The following is a description of a gene set: studied in species Homo sapiens Genes up-regulated in comparison of unstimulated dendritic cells (DC) at 0 h versus DCs stimulated with LPS (TLR4 agonist) and R848 for 8 h. from publication Napolitani G, Rinaldi A, Bertoni F, Sallusto F, Lanzavecchia A (PMID 15995707) Human Gene Set: GSE2706_UNSTIM_VS_8H_LPS_AND_R848_DC_UP Toll like receptors (TLRs) sense microbial products and initiate adaptive immune responses by activating dendritic cells (DCs). Since pathogens may contain several agonists we asked whether different TLRs may synergize in DC activation. We report that in human and mouse DC TLR3 or TLR4 potently synergize with TLR7, TLR8 or TLR9 in the induction of selected cytokine genes. Upon synergistic stimulation, IL-12, IL-23 and Delta-4 are induced at levels 50-100 fold higher than those induced by optimal concentrations of single agonists, leading to enhanced and sustained TH1 polarizing capacity. Using microarray analysis we show that only 1.5% of the transcripts induced by single TLR agonists are synergistically regulated by combinations of TLR4 and TLR8 agonists. These results identify a combinatorial code by which DCs discriminate pathogens and provide (suggest) a rationale to design adjuvants for TH1 responses. Series_overall_design: 3 untreated, 3 treated with LPS at 2h, 3 treated with LPS at 8h, 3 treated with R848 at 2h, 3 treated with R848 at 8h, 3 treated with LPS + R848 at 2h, 3 treated with LPS + R848 at 8h, and this is the list of marker genes: IVD, CNPY3, SMARCA4, TK2, RAB34, PGPEP1, MCUR1, TULP4, KLHL21, VSIR, MBNL3, DOK1, CD33 (CD33 molecule), VPS26B, MEA1, DTD1, PDCD4-AS1, ICMT, CIITA, H2AX, PPIH, CCDC102B, PKN1, ACAA1, INTS10, ACSS2, EFHD1, HDGF, USB1, SLC49A4, TTC3, EPRS1, NDUFA12, MRPL48, STAG3, TXNL4A, SLC7A8, DCLRE1C, DDX41, GPS1, INPPL1, KDM4B, CEP78, SLC8A1, ZNF581, IARS2 (NCBI Gene Id 55699), NUP85, TWF2, LEPROTL1, KLHL42, APRT, CD1C, SH2D3C, ZNF641, SLC39A10, CEP57, OCEL1, PDK3, ZNF184, GLRX5, STX10, ARSD, PON2, NHP2, ETFRF1, NSL1 (NSL1 component of MIS12 kinetochore complex), TTC7A, HAGH, UNG, TBC1D14, NFIA, IGF1R, AP1M1 (NCBI Gene Id 8907), ACAT1, SMARCC1 (SWI/SNF related, matrix associated, actin dependent regulator of chromatin subfamily c member 1), NUP133, LIN37, CTBP2, FRMD4A, NDUFA8, HK1, MPST, CARS2, ELAC2, ZMYND19, MSH6, CLSTN1, OIP5-AS1, TRAPPC2L, GRHPR, TBC1D22A, PRCP, GNPDA1, PNPO (NCBI Gene Id 55163), PLA2G12A, GSTK1, MRE11, TMEM107, TSHZ3, SPOP, VPS37A, TRIM14 (tripartite motif containing 14), RPL13A, PGM2L1, CAMK2G, IFNAR1, LBR, PHC2, CCDC107, ARL3, FAM118B, CDCA7L, ELMOD2, MRPS5, SLC12A2-DT, C11orf24 (NCBI Gene Id 53838), AGAP3, IRF2BP2, RPA1, ITFG2 (NCBI Gene Id 55846), SLC38A9, RRM2B, TPST2, SHCBP1, CLEC10A, UQCRC1, CRTAP, YIPF2, RAB33A, GMPS, CBFB, HAUS4, NDC1, HSPBAP1, IL17RA, IRF4, MRAS, MRPL11, ZNF609, SLC45A4, DENND1C, DAB2, MARCHF8, SLC4A11, DNAJC9, AQP3, PWAR5, TMEM65, TPRG1L, CCDC14, FDX2, B3GLCT, POP5, HACD2, CLEC7A (NCBI Gene Id 64581), ATP5PO, RIOX2, SAE1, PHF14, CTNS, CCDC92, MAGOH-DT, UFC1, SLC12A7, PRPSAP1, LPCAT4, MEF2D, NSMAF, MRPS9, AP4B1, CERK, FAM111A, HEBP2, PARP1, MBP, PCYOX1, FBXO31, SLC29A3, NAA40, KLHDC2, TBC1D10C, NHLRC3, BCKDK, NCKAP1L, PLSCR3, TMLHE, CALHM2, TMEM63A, RNF135, CACYBP, GTF3C5, JMY, SCAMP1, CORO1B, CCDC106, ECHDC1 (ethylmalonyl-CoA decarboxylase 1), ZNF788P, SLC41A3 (NCBI Gene Id 54946)